Given this list of marker genes PRRG4, GMNN, E2F3, MVK, CCR4, LGALS1, TUBA1B, BCL6, TXN, GPR68, NOD2, NDUFC2, KDSR, RNF135, GLB1, WIPI1, ELL2, S100A4, FADS1 (fatty acid desaturase 1), CLTC, HEXB, POMP, HMGCR, CCNE1, PCK2, DPP3, F2R, PSMB6, SURF4, TASL, SNF8 (SNF8 subunit of ESCRT-II), IDH1, SPN, ABHD4, LRRC42, TSPAN5, NUSAP1, STARD4, TUBA1C, ADAM19, LY96 (NCBI Gene Id 23643), PPIF, NRBP1, PLIN2, GLMP, SLC35D2, SPPL2A, SLC12A2, SLC35A2, H3C7, CCL5, HERPUD1, ADAM9, SNORA71C, MYO1F, LPXN, MYD88, AKIRIN2, ORAI2, CYB5B, VDAC1, LIMD1, SLC25A1, PPP1R16B, STK39 (NCBI Gene Id 27347), CKS2, ATP6V0D1, DBI (NCBI Gene Id 1622), SYT11, MVD, CENPU, PYCARD, CTNNA1, SNTB2, SEC14L1, FDPS, TFE3, H4C8, CDC20, BCKDK (branched chain keto acid dehydrogenase kinase), F8, CLIC1, PLEKHF1, H3C10, PHLDA1, H2BC14, FUT8, CACNB3, PDXDC1, WSB2, CHKA, MRPL28, LPCAT3, TFRC, TLR6, DCTN2, ARHGAP35, EZR, REEP3, CD82, TUBB4B, AIM2, SIRT2, NCEH1, H2BC8, P2RX7, TM6SF1, YEATS2, CD58, CSF1, PCBD1, CASP3, SPIRE1, PLAT, G6PD, LMO4, STOM, TRIP10, FADS2, TOP2A, AP1S1, IDE, BLM, C18orf54, KPNA2, CHEK1, CDC34, CPOX, DHCR24, SRGAP2, NFE2L3, CHP1, NCF4, CYP1B1, ITGA2, FHIP2A, PSMD3, SLC39A1, TBC1D2B, SLC1A5, SMCO4, CD2, TTC22, RDH10, TIFA, H2BC3, GBA1, NPC1, NCKAP1, CAPN1, H2BC10, MTHFD2, GPI, NSDHL, STK24, DDIAS, DCAF7, ACTN4, MAMLD1, TFDP1, NCR3, CD84 (NCBI Gene Id 8832), PIK3R3, ARHGEF12, PFKP, H3C12, VKORC1L1, NQO1, EBI3, PLEKHA5, DUSP10, ELMO1, H2BC11, ELOVL1, CLTA, PPP2R5D, PDE1B, RAD23B, TTL, INSIG1 (NCBI Gene Id 3638), MCOLN2, CTSA, SLC35B1, CTNS, COTL1, ACTA2, CLDND1, SESN2, GK, GPR15, ITGAL, UBE2A, TPP1, ARL6IP1, GPR137B, PCGF1, ASB2, CORO1C, SLC35B2, RILPL2 (Rab interacting lysosomal protein like 2), here is a description of the gene set: studied in species Homo sapiens Human Gene Set: GSE32986_UNSTIM_VS_CURDLAN_LOWDOSE_STIM_DC_DN from publication Min L, Isa SA, Fam WN, Sze SK, Beretta O, Mortellaro A, Ruedl C (PMID 22250091) A simultaneous engagement of different pathogen recognition receptors provides a tailor made adaptive immunity for an efficient defence against distinct pathogens. For example, cross talk of TLR and c-type lectin signalling effectively shapes distinct gene expression patterns by integrating the signals at the level of NF-κB. Here, we extend this principle to a strong synergism between the Dectin-1 agonist, curdlan, and an inflammatory growth factor, GM-CSF. Both together act in synergy in inducing a strong inflammatory signature which converts immature DCs to potent effector DCs. A variety of cytokines (IL-1β, IL-6, TNF-α, IL-2 and IL-12p70), costimulatory molecules (CD80, CD86, CD40 and CD70), chemokines (CxCl1, CxCl2, CxCl3, CCl12, CCl17) as well as receptors and molecules involved in fugal recognition and immunity such as Mincle, Dectin-1, Dectin-2 and Pentraxin 3 are strongly up-regulated in DC treated simultaneously with curdlan and GM-CSF. The synergistic effect of both stimuli resulted in strong IKBα phosphorylation, in its rapid degradation and in enhanced nuclear translocation of all NF-κB subunits. We further identified MAPK ERK, as one possible integration site of both signals, since its phosphorylation was clearly augmented when curdlan was co-applied with GM-CSF. Our data demonstrate that the immunomodulatory activity of curdlan requires an additional signal provided by GM-CSF to successfully initiate a robust β-glucan specific cytokine and chemokine response. The integration of both signals clearly prime and tailor a more effective innate and adaptive response against invading microbes and fungi. Genes down-regulated in bone marrow-derived dendritic cells: unstimulated versus low dose of 1,3-beta-D-oligoglucan.